Given this list of marker genes ADSS1, CHCHD10, COPA, SGCG, DNAH11, DUX4, DMD (NCBI Gene Id 548327), MT-TN, PUS1, HLA-DRB1, B3GALT6, COL13A1 (collagen type XIII alpha 1 chain), GIPC1, TOR1A, WDR19, SELENON, ARSB, TRAPPC11, ENG, TSC2, RNU4ATAC, RAPSN, BAG3, BTNL2, PRTN3, FAM111B, HCK, NKX2-1, TTN, NOTCH2NLC, HPS4, HPS1, ALMS1, DDR2, DNMT3B, LRP12, MESP2, DUX4L1, SNUPN, ACP5, DOK7, RTL1, PTPN22, GALNS, CHRNB1, CD81, NFKB1, COL2A1, STAC3, CR2, IDS, CHRND, GDAP1, DNASE1L3, CFAP410, SLC12A6, MT-TL1, TNFSF12, ICOS, PYROXD1, POGLUT1, LRP4, DOCK11, NAA10, MYH7, HES7, RILPL1, SLC34A2, PLOD1, CSF2RB (colony stimulating factor 2 receptor subunit beta), MYO1H, CHRNA1, HLA-B, DKC1 (NCBI Gene Id 1736), CTLA4 (NCBI Gene Id 3411), CD19, MEGF10, RNF168, HLA-DPB1, FLNB, NFKB2, IKZF1 (NCBI Gene Id 55429), DLK1, TNFRSF13C, MT-TL2, TNFRSF13B, NLRP3, MEG3, FARSA, TSC1, IRF2BP2, AGRN, RPA1, HLA-DPA1, BICD2, CSF2RA, GNPTAB (NCBI Gene Id 79158), PIEZO2, FGFR3, FRG1, GLB1, SYNE1, SCN4A, SFTPA1, CHRNE, FKRP, SMCHD1, MS4A1, MUSK, AK9, here is a description of the gene set: species: Homo sapiens A functional defect characterized by reduced total lung capacity (TLC) not associated with abnormalities of expiratory airflow or airway resistance. Spirometrically, a restrictive defect is defined as FEV1 (forced expiratory volume in 1 second) and FVC (forced vital capacity) less than 80 per cent. Restrictive lung disease may be caused by alterations in lung parenchyma or because of a disease of the pleura, chest wall, or neuromuscular apparatus. Restrictive ventilatory defect Human Gene Set: HP_RESTRICTIVE_VENTILATORY_DEFECT